The following is a description of a gene set: species: Homo sapiens Human Gene Set: GOMF_ORGANIC_ACID_SODIUM_SYMPORTER_ACTIVITY Enables the transfer of a solute or solutes from one side of a membrane to the other according to the reaction: organic acid(out) + Na+(out) = organic acid(in) + Na+(in)., and this is the list of marker genes: SLC10A2, SLC38A1, SLC38A2, SLC13A3, SLC23A1, SLC10A3, SLC6A5, SLC10A5, SLC6A8, SLC5A12, SLC6A9, SLC6A15, SLC5A6, SLC6A14, SLC10A1, SLC13A5, SLC6A12, SLC1A2 (NCBI Gene Id 6506), SLC6A13, SLC23A2, SLC10A4, SLC38A4, SLC13A2, SLC1A3, SLC6A1, SLC6A6, SLC38A7, SLC6A20, SLC1A1, SLC6A7, SLC6A11, SLC5A8, SLC1A6, SLC1A7, SLC10A6